The following is a description of a gene set: Human Gene Set: GOBP_SMOOTH_MUSCLE_TISSUE_DEVELOPMENT studied in species Homo sapiens The process whose specific outcome is the progression of smooth muscle over time, from its formation to the mature structure., and this is the list of marker genes: STRA6, SOX9, MIR145, COL3A1, NF1, EFEMP2, BMP4, TNN, IHH, DLG1, MYLK, OSR1, PTCH1, NPR2 (NCBI Gene Id 4882), SRF, TFAP2B, PROX1, FOSL2 (FOS like 2, AP-1 transcription factor subunit), MIR143, SIX1, ITGA8, SHH, PKD2, ZFAND5, SMO, TIPARP, FOXP2, ENG